Given this list of marker genes OPTN, CERT1, ADAMTSL3, TEAD3, MYBPC3 (NCBI Gene Id 4607), VPS13D (vacuolar protein sorting 13 homolog D), TFE3, GPR87, RP2, RSPO1, KLHL2, CDH10, SNED1, LIMS4, ATXN1L, MCU, NTNG1, ASPM, COL4A6, NPTX1, PCSK7, CIB4, HIC2, SLC7A5, MTARC1, APOA4, SCCPDH, UBE2S, PHF10, GIPR, SKA2, PLA2G3, CCN5, RNF19B, AMPD2, SMOX, API5, TACC3, CAPNS1, HOXA7, GNA15, ARRB1, PEDS1, NKIRAS2, NRIP2 (nuclear receptor interacting protein 2), CENPL, LRRC8D, DLL3, PTPRK, MPZL1, RAD51AP1, FHIP2A, TPST2 (tyrosylprotein sulfotransferase 2), DMTN, NACAD, S100A1, RAB24, NAA60, NETO2 (neuropilin and tolloid like 2), AVPR1A, CREG1, CSNK1E, LGI3, MAP1LC3A, ITK, YAP1, PLA2G2E, DHRS1, ATP6V0D1, SPRY4, ZFAND3, VASP, ARHGEF25, ACAD8, CRAT, TSPOAP1, ZNRF1, GSTA5 (glutathione S-transferase alpha 5), PBXIP1, SLC6A12, LXN, CDC20, C1QA, POU2F3, APLNR, CEACAM20 (CEA cell adhesion molecule 20), NABP2, MTHFD2, LAMC2, IQGAP3, MID1IP1, ELOVL1, ADA, CEMIP2 (cell migration inducing hyaluronidase 2), KCNK12, PIGX, CLCA2, TCF21, EPHA1, PDZD8, LHFPL4, CYP26A1, UBTD1, STK36, PIK3R5, TRAPPC2L, PRKRA, HLX, HRG, ABCD3, IL18BP, ARF1, SERPINB6, ARHGEF4, MEP1B, TMPRSS4, SLC5A5, HJURP, LYPD4, GZMA, MPC2, CCNYL1, SLC22A12 (solute carrier family 22 member 12), PACS2, BCORL1, MARCHF10, BMPR2, FARP1, ANKRD24, NPHS2, HAND1, CEP76, CWH43, RBM47 (NCBI Gene Id 54502), GIP, GNG13, PSEN1, C9, ANXA7, ZDHHC15, COQ8B, TRIQK, CNNM3, PRR22, FBXO3, PRR32, VWF, CCDC102A, PRKAB1, ENTPD5, SP7, GPC1, SLCO3A1, SSU72, PDCD6IP, PCDH18, NRSN2, GDF9 (growth differentiation factor 9), ST3GAL4 (NCBI Gene Id 80040), SMO, CLINT1, MYO1H, ALOXE3, DSTYK, GPR35, CDKL2, SERF2, MAN2B1, CAMK2G, PIGZ, ZNF469, PRC1, TRAPPC2, CORO1C (coronin 1C), GSDMD, SEL1L3, TMEM181, WWC1, RHOG, GAMT, TM6SF1, KLRD1, PKMYT1, CITED2, GGH, MCF2L, GAB2, HOMEZ, ACTL10, IKBKE, CD84, PPP1R15B, MZT2B, CCDC34, SPATS2, LHFPL2, E2F8, AFF2, MINDY1, SASS6, here is a description of the gene set: Human Gene Set: GSE27786_BCELL_VS_MONO_MAC_DN from publication Konuma T, Nakamura S, Miyagi S, Negishi M, Chiba T, Oguro H, Yuan J, Mochizuki-Kashio M, Ichikawa H, Miyoshi H, Vidal M, Iwama A (PMID 21540074) Genes down-regulated in comparison of B cells versus monocyte macrophages. Each fraction of mouse hematopoietic cells was purified by cell sorting from bone marrow of 8-week-old C57BL/6 mice, and its gene expression was analyzed. species: Homo sapiens